Given this list of marker genes TSGA10IP, TMEM231 (NCBI Gene Id 79583), TMEM17, CFAP53, RPGR, INTU, CDKL1, POC5, AHI1, TRAF3IP1, TCTN1, NPHP1, TOPORS, MYO7A, NEK4, BBS4, ARL3, PCM1, CEP290, TBCC, TMEM80, BBS9 (Bardet-Biedl syndrome 9), CFAP36, CIBAR1, CIBAR2, CC2D2A, PCDHB15, WDR19, B9D2, TMEM107, CETN1, MAK, NPHP4, LCA5, CC2D2B, KIFAP3, DYNC2LI1, B9D1, FAM161A, GNAT1, MKS1, TMEM216, TTBK2, IQCB1, RP1L1, RP1, CPLANE2, CCDC66, CCSAP, USH1G, IFT57, IFT140, USH2A, KIAA1549, TTC8, CFAP410, CPLANE1, TMEM67 (transmembrane protein 67), SPATA7, UNC119B, SPTBN5, MACIR, IFT52, RPGRIP1L, TCTN2, TMEM237, KIF17, IFT122, CETN2, CEP131, IFT20, PCDHB13, RAB37, CETN3, SEPTIN2, WHRN, RPGRIP1, here is a description of the gene set: species: Homo sapiens Human Gene Set: GOCC_CILIARY_TRANSITION_ZONE A region of the cilium between the basal body and proximal segment that is characterized by Y-shaped assemblages that connect axonemal microtubules to the ciliary membrane. The ciliary transition zone appears to function as a gate that controls ciliary membrane composition and separates the cytosol from the ciliary plasm.